The following is a description of a gene set: part of: SLC-mediated transmembrane transport Myo-Inositol is a neutral cyclic polyol, abundant in mammalian tissues. It plays important roles; it is a precursor to phosphatidylinositols (PtdIns) and to the inositol phosphates (IP), which serve as second messengers and as key regulators of many cell functions. It can also serve as a compatible osmolyte during volume regulation in many tissues where cells are exposed to hyperosmotic conditions. Three members of the glucose transporter families are inositol transporters. Two (SMIT1 and SMIT2) couple myo-inositol transport with two Na+ ions. Unlike SMIT1, SMIT2 also transports D-chiro_inositol. The third transporter (HMIT), couples myo-inositol transport with a proton. species: Homo sapiens Reactome Pathway: Inositol transporters, and this is the list of marker genes: SLC5A11, SLC5A3, SLC2A13